Given this list of marker genes Slc25a18 (solute carrier family 25 (mitochondrial carrier), member 18), Slc1a1 (NCBI Gene Id 319379), Slc1a5, Ucp2, Slc25a12, Slc25a13, Slc13a3, Slc1a4, Slc25a22, Slc1a6, here is a description of the gene set: Mouse Gene Set: GOMF_L_ASPARTATE_TRANSMEMBRANE_TRANSPORTER_ACTIVITY Enables the transfer of L-aspartate from one side of a membrane to the other. L-aspartate is the anion derived from aspartic acid. studied in species Mus musculus